Given this list of marker genes Usp2, Tnfrsf1a, Ulk1, Uba52rt, Traf1, Birc3, Ubc, Rbck1, Clip3, Ikbke, Ube2d1, Xiap, Ube2d2a, Chuk, Sppl2a, Ikbkb, Sppl2b, Cyld, Usp21, Tax1bp1, Rps27a, Uba52, Tradd, Otud7b, Ube2d3, Casp8, Traf2, Otud1, Madd, Tnfaip3, Fadd, Rack1, Mapkapk2, Ripk1, Mib2, Optn, Ube2l3, Stub1, Birc2, Tnf, Spata2, Ikbkg, Ubb, Rnf31, Tbk1, Usp4, Cflar, here is a description of the gene set: Mouse Gene Set: REACTOME_REGULATION_OF_TNFR1_SIGNALING species: Mus musculus Regulation of TNFR1 signaling